The following is a description of a gene set: Human Gene Set: GOBP_CELL_REDOX_HOMEOSTASIS Any process that maintains the redox environment of a cell or compartment within a cell. species: Homo sapiens, and this is the list of marker genes: NFE2L2, TXNDC2, TXN2, KRIT1, GPX1, EGLN2, GLRX5, SELENON, NOS1, ERO1A, DDIT3, HVCN1, CHD6, BOLA2, PRDX6, PRDX3, PRDX4, GIT1, NQO1, PRDX5, NNT (NCBI Gene Id 23530), BOLA3 (bolA family member 3), SLC11A1, ERO1B, GSR, ERP44, SELENOT, PRDX1, NOS2, APEX1, NFE2L1, SLC2A10, SELENOS (NCBI Gene Id 55829), BOLA1, GLRX3, TXN, GCLC, BOLA2B, TXNRD2, TXNRD3, PRDX2, NOS3, TXNRD1, GLRX2